Given this list of marker genes ANAPC7, UBE2B, ANAPC13, ASB11, ANAPC1, FZR1, ANAPC11, UBE2D4 (NCBI Gene Id 82030), ANAPC2, CDC16, UBE2H, UBR4, UBE2T, UBR5, CUL5, UBE2L3, UBE2L5, TRIM26, RNF4, UBE2A, ANAPC15, RNF7, CDC26, ANAPC16, UBE2W, CDC23, CDC27, ANAPC4, UBE2D3, UBE2E3, ANAPC5, RNF115, PRKN, ANAPC10, UBE2S, AREL1, UBE2E2, UBE2C, RNF26, here is a description of the gene set: studied in species Homo sapiens Human Gene Set: GOBP_PROTEIN_K11_LINKED_UBIQUITINATION A protein ubiquitination process in which ubiquitin monomers are attached to a protein, and then ubiquitin polymers are formed by linkages between lysine residues at position 11 of the ubiquitin monomers. K11-linked polyubiquitination targets the substrate protein for degradation. The anaphase-promoting complex promotes the degradation of mitotic regulators by assembling K11-linked polyubiquitin chains.